The following is a description of a gene set: Human Gene Set: GOBP_REGULATION_OF_CARDIAC_MUSCLE_CELL_MEMBRANE_POTENTIAL Any process that modulates the establishment or extent of a membrane potential in a cardiac muscle cell (a cardiomyocyte). A membrane potential is the electric potential existing across any membrane arising from charges in the membrane itself and from the charges present in the media on either side of the membrane. studied in species Homo sapiens, and this is the list of marker genes: EHD3, TRDN, ATP2A2 (ATPase sarcoplasmic/endoplasmic reticulum Ca2+ transporting 2), SLC9A1, PLN, SLC8B1, FXYD1